The following is a description of a gene set: species: Homo sapiens Genes having at least one occurence of the motif GTCTTCC in their 3' untranslated region. The motif represents putative target (that is, seed match) of human mature miRNA hsa-miR-7 (v7.1 miRBase). Human Gene Set: GTCTTCC_MIR7, and this is the list of marker genes: CKAP4, NR1H2, GLI3, CSMD3, MIER2, SCN2B, OSBPL11, SMG1, CHSY3, SP1, SMARCD1 (NCBI Gene Id 6602), PTK2, SKP1, VPS26A, DYRK1A, FAM53C, KCNJ2, PLAG1, SEMA6D, SLC38A2, SELENOS, AGO1, IGF2BP2, MFN1, CLIP3, ZNF609, ERBB4, G3BP2 (NCBI Gene Id 9908), ATXN1, ACSL4, PATL1 (PAT1 homolog 1, processing body mRNA decay factor), NLGN2, BACE1, KMT5A, KLF4, CALU, VMA21, CHAMP1, CLASP2, AMBRA1, PLP2 (NCBI Gene Id 5355), ANKRD12, MAPK4, GABBR1, SCAMP5, CA7, EPHA8, SLC4A4, CCSER2 (coiled-coil serine rich protein 2, NCBI Gene Id 54462), PLXNA1, PBX3, SRGAP2, PDE4D, SMYD5, SERP1, STIMATE, CNNM4, CNOT8 (NCBI Gene Id 9337), OXR1, MKNK1, WDR47, RAB5IF, ATP2B2, CNN3, ANKFY1, HELLS, PHAF1, ITCH, RBFOX1, ZBTB22, FAM83D, COL2A1, WAPL, PAX6, PAN2, ASXL1 (ASXL transcriptional regulator 1), ARL8B, TRMT13, ELFN2, DIRAS1, SRRM3, SLC38A4, PLEC, GAL3ST3, CNPPD1, FOXN3, CRY2, ADAM11, RPS6KB1, NR4A3 (nuclear receptor subfamily 4 group A member 3), FLRT2, SLC25A15, PCSK7, STRN3, FAM168B, PFN2, OGT, CCDC43, SHANK2, OSBPL5 (oxysterol binding protein like 5), ESRRG, ABCG4, HERPUD2, LRRC8A, SEMA4C, BOC, DNMT3A, PIM1, MAP3K9, MARF1, CGGBP1, CYTH3, CCNT2, MAP4, HYCC2, SRSF5, ABHD8, RNF20, TBC1D10B, ARF4, BICRA, CAPZA1, TMED9, DDIT4 (DNA damage inducible transcript 4), LEMD3, RGS7BP, ZNF395, PPFIA3, PURB, TCF12, WIPF2, KLF12, PRKCB, USF3, DACH1, VDAC1, SLC8A3, SLC6A9, LTN1, PIK3CD, EGR3, HOXB5, RAF1, RNF114, ARID4A, PHF21A, RSBN1, HPCAL4, POLE4, IRS2, LZTS3 (NCBI Gene Id 9762), CHD3, RNF141, UBE2D2, MOB1B, MAPKAP1, IPO11, SPATA2, EPHA3, TFRC, ADCY9, NREP, LRRC59, RNF144A, CACNA2D4, UBLCP1, MAFG, SRF, SATB1